Given this list of marker genes Shd (NCBI Gene Id 20420), Ahcyl, Fkbp7, Arpc1a, Pdcd6, S100a1, Iars2, Ebf1, Hmgn2, Idh1, Plekho1, Gstk1, Rpl13a, Idh2, Cks2, Tmem176a, Cirbp, Snapc2, Fars2, Phpt1, Rbmx, Ifnar2, Decr1, Gng11, Fxyd2, Rbp1, Nap1l1 (nucleosome assembly protein 1-like 1), Zftraf1, Mcm3, Qars1, Ptgr1, Gna12, Ensa, Ggh, Nsdhl (NAD(P) dependent steroid dehydrogenase-like), Wdr83os, Casp8, Ergic3 (NCBI Gene Id 99284), Mpdu1, C1qb, S100a11, Emp3, Slc39a8, H2-T10, Akr1b8, Rab3d (NCBI Gene Id 83761), Maged2, Pcx, Ntpcr, Fdft1, Hsd17b10, Nudt21, Hikeshi, Mdk, Arl6ip5, Pcp4, Psme1, Antxr2, Elovl6, Atp6ap2, Fkbp9, Gnai2, Rpa3, Rras, Exoc4, Cln6, Rbms2, Chpt1 (choline phosphotransferase 1), Acp1 (NCBI Gene Id 80477), Oxct1, Ptgis, Cd44, Trim17, H2bc4, Higd2a, Capns1, Trim59, Aldh2, Pik3c3, Ntan1, Lgals3bp, here is a description of the gene set: Human infertility and recurrent pregnancy loss caused by implantation defects are poorly understood. Hoxa-10-deficient female mice have severe infertility and recurrent pregnancy loss due to defective uterine implantation. Gene expression profiling experiments reveal that Hoxa-10 is an important regulator of two critical events in implantation: stromal cell proliferation and local immunosuppression. At the time of implantation, Hoxa-10 mediates the progesterone-stimulated proliferation of uterine stromal cells. Hoxa-10 mutants express a stromal cell proliferation defect that is accompanied by quantitative or spatial alterations in the expression of two cyclin-dependent kinase inhibitor genes, p57 and p15. Hoxa-10 deficiency also leads to a severe local immunological disturbance, characterized by a polyclonal proliferation of T cells, that occurs in place of the normal progesterone-mediated immunosuppression in the periimplantation uterus. Genes co-regulated in uterus during a time course response to progesterone: SOM cluster 12. studied in species Mus musculus Mouse Gene Set: YAO_TEMPORAL_RESPONSE_TO_PROGESTERONE_CLUSTER_12 from publication Yao MW, Lim H, Schust DJ, Choe SE, Farago A, Ding Y, Michaud S, Church GM, Maas RL (PMID 12554760)